Given this list of marker genes Pcdh15, Map1a, Inha, Map1b, Arr3, Cnga1, Phlpp2, Prom1, Gnb1, Mak, Gucy2e, Cerkl, Lyar, Pde6b (NCBI Gene Id 18587), Tulp1, Bbs7, Pde6a, Prkca, Cfap410, Impg1, Cacna1f, Opn5, Rdh11, Stx3, Shank2, Myo7a, Opn3 (opsin 3), Cib2, Pcdhb16, Ift20, Mertk, Pip4k2a, Slc24a4, Cdhr1, Ptprk, Rom1, Ccdc66, Nup42, Magi2, Ush1c, Ptgs1, Kif17, Crb1, Rpgr, Atp1a4, Prph, Nxnl1, Pcare, Rcvrn, Myrip, Pex6, Rp1, Ift140, Rp1l1, Guca1b, Bsg, Cngb3, Cngb1, Sag, Cnga3, Sptbn5 (NCBI Gene Id 640524), Kifap3, Opn1sw, Abca4, Vcan, Pdc, Pde6g (phosphodiesterase 6G, cGMP-specific, rod, gamma), Prcd, Pde6h, Cep250, Hnf1a, Rho, Iqcb1, Ahi1, Myo5a, Gucy2f, Myo3b, Prph2, Bbs4, Rapgef4, Tmem237, Ocrl (OCRL, inositol polyphosphate-5-phosphatase), Guca1a, Rd3, Opn1mw, Gnat1, Rab27a, Gnat2, Plekhb1, Grk1, Wdr19, Spata7, Cep290, Gngt1, here is a description of the gene set: studied in species Mus musculus Mouse Gene Set: GOCC_PHOTORECEPTOR_OUTER_SEGMENT The outer segment of a vertebrate photoreceptor that contains a stack of membrane discs embedded with photoreceptor proteins.